Given this list of marker genes Terf2ip, Terf2, Stn1, Pot1a, Ten1, Terf1, Ctc1, Pola2 (NCBI Gene Id 18969), Acd, Pola1, Prim2, Prim1, here is a description of the gene set: Mouse Gene Set: REACTOME_TELOMERE_C_STRAND_SYNTHESIS_INITIATION studied in species Mus musculus Telomere C-strand synthesis initiation